Given this list of marker genes LMO4 (NCBI Gene Id 8543), PTCH1, DLL1, NKX2-2 (NK2 homeobox 2), NOTCH1, MTA3, SFRP2, EOMES, PRDM14, IHH, GLI3, MYL2, NRP1, HOXC10, DBX1, RBPJ, PAX6, GLI2, TBXT, PAX2, RBBP4, SIX1, FOXA1, PSEN1, DHH, GSX2, PTCH2, ITGB1, MIR125A, ISL1, HOXA11, HDAC1, SUFU, FZD7, SIX2, TBX18, MTA2, SOX2, HOXD10, TEAD4, FGFR1, NODAL, TBX21, GATAD2A, HNF1B, TBX10, MTA1, ESRP1, EHMT2, TBX19, SMO, RBBP7, HOXA13, SOX1, DKK1, TBX15, BMPR1A, HDAC2, CDON, MNX1, MESP1, TBX22, SOX9, GSC, GATAD2B, CHD3, TBX1, TBR1, POU3F2, DMRT3, SOX17, FOXA2, CHD4, ISL2, OLIG3, POU4F1, SOX18, TBX6 (T-box transcription factor 6, NCBI Gene Id 6911), POU5F1, CTNNB1, FGF2, TBX2, SHH, NFIB, TBX4, ASCL1, MGA, NKX2-3, OLIG2, TBX20, LHX3, FOXI3, WNT3A, MBD3, EYA2, TBX5, SMAD4, MYT1L, NFIA, ATOH1 (atonal bHLH transcription factor 1, NCBI Gene Id 474), EYA1, DMRTA2, APC, NTRK3, FKBP8, NANOG, FEV, TENM4, TLX3, APC2, TBX3, here is a description of the gene set: species: Homo sapiens The cellular developmental process involved in cell fate commitment in which the cell is designated to follow a developmental path, unless they receive extrinsic cues that direct an alternative fate. Human Gene Set: GOBP_CELL_FATE_SPECIFICATION